Given this list of marker genes SF3B4, POLR1D, POLR1B (NCBI Gene Id 88998), TSC1, TCOF1, POLR1C, here is a description of the gene set: studied in species Homo sapiens Human Gene Set: HP_PREAURICULAR_HAIR_DISPLACEMENT An tongue-like extension of hair towards the cheeks, in which hair growth extends in front of the ear to the lateral cheekbones. Preauricular hair displacement